The following is a description of a gene set: EEG with focal spikes EEG with focal sharp transient waves of a duration less than 80 msec. Human Gene Set: HP_EEG_WITH_FOCAL_SPIKES species: Homo sapiens, and this is the list of marker genes: PDHA1, CABP4, PIGG, SCN2A, ARHGEF9, CHRNB2, CHRNA4, CHRNA2, TFE3, ADGRG1, DEPDC5, LONP1, SYT1, CNTNAP2, MTOR, KCNQ2, KCNT1, PI4KA, SPTAN1, GRIN2A, AKT3, SRPX2, CRH (NCBI Gene Id 1392), CLCN4, GNB1, PIK3CA